Given this list of marker genes GATD1, PNKD, PARK7, GLO1, HAGH, TPI1, here is a description of the gene set: Human Gene Set: GOBP_METHYLGLYOXAL_METABOLIC_PROCESS The chemical reactions and pathways involving methylglyoxal, CH3-CO-CHO, the aldehyde of pyruvic acid. species: Homo sapiens